Given this list of marker genes Slc17a8, Ntsr1, Arhgef11, Slc1a6, Tnf, Septin2, Kcnj10, Psen1, Itgb1, Arl6ip5, Per2, Cln8, Arl6ip1, Grm1, Slc7a11, Slc1a1, Slc1a3, Slc1a2, here is a description of the gene set: studied in species Mus musculus Mouse Gene Set: GOBP_L_GLUTAMATE_IMPORT_ACROSS_PLASMA_MEMBRANE The directed movement of L-glutamate from outside of a cell, across the plasma membrane and into the cytosol.